Given this list of marker genes Calm2, Calm3, Prkar1b, Rps6ka2, Gria4, Rps6ka6, Camkk2 (NCBI Gene Id 207565), Dlg2, Prkacb, Prkar1a, Lrrc7, Camk2g, Grin1, Grin2a, Dlg4, Gria2, Grin2d, Camk2b, Dlg3, Creb1, Rps6ka3, Grin3a, Calm1, Camk2a, Camk1, Prkaca, Gria3, Gria1, Actn2, Camk2d, Dlg1, Grin2c, Camkk1, Rps6ka1, Nefl, here is a description of the gene set: Activation of NMDA receptors and postsynaptic events species: Mus musculus Mouse Gene Set: REACTOME_ACTIVATION_OF_NMDA_RECEPTORS_AND_POSTSYNAPTIC_EVENTS